Given this list of marker genes Safb2 (scaffold attachment factor B2), Smarca4, Rnf6, Ncor2, Trim68, Igf1, Nodal, Prmt2, Ddx5, Ep300, Phb1, Sfrp1, Esr2, Sirt1, Dab2, Kdm5d, Tcf21, Heyl (NCBI Gene Id 56198), Rnf14, Safb, Shq1 (NCBI Gene Id 72171), Pias2, Foxh1, Park7, Zbtb7a, Hdac1, Usp26 (NCBI Gene Id 83563), Foxp1, Ncor1, Pten, here is a description of the gene set: species: Mus musculus Any process that modulates the rate, frequency, or extent of the androgen receptor signaling pathway. Mouse Gene Set: GOBP_REGULATION_OF_ANDROGEN_RECEPTOR_SIGNALING_PATHWAY